The following is a description of a gene set: The series of events that restore integrity to damaged tissue that contribute to an inflammatory response. species: Mus musculus Mouse Gene Set: GOBP_WOUND_HEALING_INVOLVED_IN_INFLAMMATORY_RESPONSE, and this is the list of marker genes: Tlr4, Clec10a, Hmox1, Timp1, Lrrc25, Ccr2, Hif1a, Cd44, F2r, Pparg, Il1a (NCBI Gene Id 16175)